Given this list of marker genes Upf3b, Srsf12, Snrpc, Cactin, Exosc10, Prpf39, Srsf7, Upf3a, Ncbp2, Wbp4, Psip1, Sart1, Srsf1, Cwc15, Prpf4b, Clns1a, Sfswap, Prpf40b, Rbm17, Dcps, Prpf40a, Eif1, Sde2, BC005624, Rbm22, Sf3a1, Upf1, Srsf3, here is a description of the gene set: studied in species Mus musculus The joining together, after removal of an intervening sequence composed of one or more introns, of two segments of the same RNA molecule via spliceosomal catalysis to produce an mRNA composed only of exon sequences that all came from the same primary transcript. Mouse Gene Set: GOBP_MRNA_CIS_SPLICING_VIA_SPLICEOSOME